The following is a description of a gene set: Genes predicted to be targets of miRBase v22 microRNA mmu_miR_7218_5p in miRDB v6.0 with MirTarget v4 prediction scores > 80 (high confidence targets). species: Mus musculus from publication Chen Y, Wang X (PMID 31504780) Mouse Gene Set: MIR_7218_5P, and this is the list of marker genes: Ccdc116, Cideb, Wnt5a, Fam117b, Rtn4, Zfp235, Cep170, Gucy1a2, Prrt2, Abl2, Abca2, Lrch3, Taf9b, Cers5, Ttn, Gss, Sh3pxd2a, Camk1d, C2cd4c, Tmem145, Neto1, Szrd1, Astl (astacin like metalloendopeptidase), Arnt2, Mfsd6, Marchf9, Vwa5a, Htr5a, Slc44a5, Psg19, Ahcyl1, Cryl1, St8sia2, Plag1, Slc4a5, Cyp4a31, Ccdc9b, Gspt1, Cyp4a10, Irak1, Zfp710, Meltf, Bphl, Hexim1, Coro2b, Lgals12, Septin4, Trim45, Tmem150b, Haus4, Rtf1, Map6d1, Camkv, Zfp267, Hnrnpul2, Sulf1, Cacna1c (calcium channel, voltage-dependent, L type, alpha 1C subunit), Atg16l1, Carmil1, Jade2, Colq, Ttll9, Zc3h4, Megf11, Arih2, Il33, Ppm1k, Avil (NCBI Gene Id 11567), Nrp1, Sst, Ptprb, Ecel1, Fam43b, Nr6a1, Cd209a, Cldn9, Ttc7, Amz1